The following is a description of a gene set: Human Gene Set: HP_REDUCED_RENAL_CORTICOMEDULLARY_DIFFERENTIATION Reduced differentiation between renal cortex and medulla on diagnostic imaging. Reduced renal corticomedullary differentiation species: Homo sapiens, and this is the list of marker genes: CLCN7, PKHD1, CEP290, NIPBL, DZIP1L, TULP3, ACTN4, IFT140, BSND, VPS33B, PDCD6IP, DCDC2, UMOD, DHX16, TMEM67